Given this list of marker genes Dlat, Ldha, Slc16a1, Slc16a3, Ldhc, here is a description of the gene set: Mouse Gene Set: GOBP_PYRUVATE_CATABOLIC_PROCESS The chemical reactions and pathways resulting in the breakdown of pyruvate, 2-oxopropanoate. studied in species Mus musculus